Given this list of marker genes Slc17a1, Slc26a1, Slc12a2, Slc4a10, Slc26a6, Slc12a5, Slc4a2, Slc26a7, Slc13a4, Slc26a4, Slc5a8 (solute carrier family 5 (iodide transporter), member 8), Ahcyl2, Slc4a1 (NCBI Gene Id 20533), Slc4a4, Slc26a9, Slc4a8, Slc12a4, Slc13a1, Slc26a11, Slc20a2, Slc26a2, Slc4a9, Slc12a3, here is a description of the gene set: part of: SLC-mediated transmembrane transport species: Mus musculus This event has been computationally inferred from an event that has been demonstrated in another species.<p>The inference is based on the homology mapping from PANTHER. Briefly, reactions for which all involved PhysicalEntities (in input, output and catalyst) have a mapped orthologue/paralogue (for complexes at least 75% of components must have a mapping) are inferred to the other species. Reactome Pathway: SLC-mediated transport of inorganic anions electronically inferred by orthology from the curated human pathway